The following is a description of a gene set: Human Gene Set: GOBP_CHEMOKINE_C_X_C_MOTIF_LIGAND_1_PRODUCTION The appearance of chemokine (C-X-C motif) ligand 1 due to biosynthesis or secretion following a cellular stimulus, resulting in an increase in its intracellular or extracellular levels. studied in species Homo sapiens, and this is the list of marker genes: IL17F, MYD88, TIRAP, TRPV4, IL17A, IL17RA